Given this list of marker genes Srf, Mlx, Suv39h1, Usf1, Kat2b, Ogt, Sik2, Mlxipl, Sirt1, Rrp8, Usf2, here is a description of the gene set: Any process involving glucose that modulates the frequency, rate or extent or transcription. species: Mus musculus Mouse Gene Set: GOBP_REGULATION_OF_TRANSCRIPTION_BY_GLUCOSE